The following is a description of a gene set: Mouse Gene Set: CHYLA_CBFA2T3_TARGETS_UP While a number of DNA binding transcription factors have been identified that control hematopoietic cell fate decisions, only a limited number of transcriptional corepressors (e.g., the retinoblastoma protein and the nuclear hormone corepressor) have been linked to these functions. Here, we show that the transcriptional corepressor Mtg16 (myeloid translocation gene on chromosome 16), which is targeted by t(16;21) in acute myeloid leukemia, is required for hematopoietic progenitor cell fate decisions and for early progenitor cell proliferation. Inactivation of Mtg16 skewed early myeloid progenitor cells toward the granulocytic/macrophage lineage while reducing the numbers of megakaryocyte-erythroid progenitor cells. In addition, inactivation of Mtg16 impaired the rapid expansion of short-term stem cells, multipotent progenitor cells, and megakaryocyte-erythroid progenitor cells that is required under hematopoietic stress/emergency. This impairment appears to be a failure to proliferate rather than an induction of cell death, as expression of c-Myc, but not Bcl2, complemented the Mtg16(-/-) defect. studied in species Mus musculus Genes up-regulated in immature bone marrow progenitor cells upon knock out of CBFA2T3. from publication Chyla BJ, Moreno-Miralles I, Steapleton MA, Thompson MA, Bhaskara S, Engel M, Hiebert SW (PMID 18710942), and this is the list of marker genes: Slco3a1, Fnbp1l, Dsg1b, Tmem144, Gca, Tcn2, Tpm4, Grpel2, Gpt2, Bpifc, Vpreb3 (V-set pre-B cell surrogate light chain 3), Dram1, Krt18, Cebpe, Zfp111, F2rl3, Gpr171, C1ra (NCBI Gene Id 50909), F10, Gpr15lg, Tbxa2r, Arhgef2, Fcor, Plod3, Adap1, Smyd4 (NCBI Gene Id 319822), Cracr2b, Slc32a1, Acsbg3, Dusp2, Gstm3, Lpgat1, F2r, Igsf6, Nemp1, Plcg2, Parp8, Prtn3, Ppia, Cd300lg, Tcea2, Ms4a3, Trap1a, Lgr5, Chd9, Bace1, Gm13710, Ttc39c, Prss16, Tmem119, Peli2, Ctsc, Nostrin, 2210408F21Rik, Itm2a, Man1c1, Trem1, Arid5a, Tifab, Ptger2, Npl, 4930417H01Rik, Nr5a1os, H2-Aa, Alox5ap, Idh1, Nkg7, Ear6, Rhobtb1, Cask, Sun2, Ptgs1, Dstn, Eepd1, Clec4d, Afap1l1, Arhgdib, Tfec, Rassf8, Ero1b, Cpne3, Lyzl1, Poglut3, Plpp2, Cables1, Serpina3g, E230032D23Rik, Rsph9, H2bc22, Ubash3b, Fbp1, Tmem53, Slc6a19os, Ucn, Trf, Cdin1, Tek, Casp1, Ldhb, Or2a14, Nav2, Ikbke (inhibitor of kappaB kinase epsilon), Esam (endothelial cell-specific adhesion molecule), Ffar2, Egln3, 1700025G04Rik, Mgst2 (NCBI Gene Id 211666), Mrgpra2b, Trim45, Hvcn1, Tlr12, Cldn15, Mgam, Rab44, Rbpms, Mctp1, Tcirg1, Klf8, Or5ac20, Ass1, Gadd45b, Galk2, Atrnl1, Hes5, Prg3, Ldlrad3, Aatk, BC028528 (cDNA sequence BC028528), Dock9, Pkd1l3, Gchfr, Taf5l, Msantd3, Tmem38b, Unc93b1, Hsd17b1, Bcr, Gfi1, P2rx7, Gbp3, Notch3, Klrb1c, Adgrl4, Id1, Slpi, Appl2, Kcnip3, Rab11fip5, Atp13a2, Alas1, Sla2, Sting1, Nr1h3, Rab31, Fcgr3, Cxxc5, Endou, B3gnt8, 4930486L24Rik, Siglecf, Celf2, Nek6, Zxdc (ZXD family zinc finger C), Mast4, Nrg4, Klkb1, Fkbp11, Ldhc, Elane, Tnfrsf26, Cuedc1, Clec5a, Cyp2j6, Ctsg, Prodh, Tet2, Gzmd, Adgrg3, Cd34, App, Sgms2, Slc35b4, Platr25, 4833407H14Rik, Scamp5, Anxa3, 4930555A03Rik, Sstr2, Plekha2, Olr1, Pam, Cemip2, Mdga1, Ccm2l, Pde2a, Serpina3b, Acod1, Igll1, Ctf1, Plekha1, Ncf2, Mtf2, Hdc, Rnase2a, Hoxb2, Ccnd2, Cd93, Mfng, Slc36a3os, Cxcr4 (NCBI Gene Id 12767), Calr, Il5ra, Dntt, Bambi-ps1, Hnmt, Cd209d, Gmpr, Ggta1, Mcub, Gm5111, Fcgr2b, Gm39348, F13a1, Slc7a6, Thnsl2, Ank3 (ankyrin 3, epithelial), Calml4, Nim1k, Stard8, Tmem141, Mfsd13a, Cideb, Cyth4, 2210406H18Rik, Slc16a9, Phf21a, Sh3bgrl2, Ccdc102a, Cd48, Pld4, Slco4a1, A430019L02Rik, Adss1, Itih5, Sptan1, Stox1, Mir223hg (NCBI Gene Id 100038363), Sh3tc1, Plppr3, Sox13 (SRY (sex determining region Y)-box 13), Ppm1k, Septin6, Pxylp1, Alpk1, Gria3, Gfra1, Arhgef3, Gm48691, Fabp5, Ehd3, Tmem150b, Kalrn, Anxa5, Evi2b, Pgam1, Itpkb, Cfap57 (NCBI Gene Id 77131), Ttpa, Ebf1, Rag1, Mta3, Nalcn, BC035044, Cebpb, Upk3bl (uroplakin 3B-like), Trem3, Arl11, D130052B06Rik, Serpinb2, Depp1, Lrp12, Ebi3, Hk3, Gbx2, Vpreb1b, Prss57, Hp, Rab27a, Homer3, Serpina3m, Cxxc4, Lbp, Gm19590, Ppbp, Tmed3, Dnmbp, Tslp, Arhgef6, Ppp1r14a, Lcp1, Flt1, Lmo1, Socs2, Tnfaip8, Gm36017, Tnfrsf12a, Rasgrp2, Gstm2, Ly6i, Cxcr6, Klhl5, Tsc22d3, Krt7, Or1j10, Clec12a, Abcg1, Nrg1, Slc4a8, Vsig10l, Tesmin (NCBI Gene Id 17771), Gstm1, Atp8b4, Ncf4 (neutrophil cytosolic factor 4), Tmod1, Vat1, Gpr65, Gpr160, 2010013B24Rik, Spef1, Ptprj, 1700040D17Rik, Atp10a, Mgl2, Slc28a2, Ppp1r3b, Laptm5, Rin3, Mefv, Rab27b, Uaca, Zfp709, S100a11, Get1, B4galnt4, Fndc3b, Hivep3, Spns3, Cerox1 (NCBI Gene Id 72834), Serpinb10, Spi1, Ralgps2, Slamf1, Mogat2, Zc2hc1a, Abcd2, Tle6, Vill, Gzma, Bex1, Rnf180 (NCBI Gene Id 71816), 2310075C17Rik, Ccdc125 (NCBI Gene Id 76041), 1700020L24Rik, Stox2, Gmfg, Sptbn1, Ramp1, As3mt, Rhoq, Ern1, Ralb, Thada, Snx24, Cst7, Cx3cr1, Map3k15, Ctla2b, Cda, Elovl7, Csrnp1 (NCBI Gene Id 215418), Cyp2j9, Golga5, Hpgd, Serpinb1a, Gas7 (NCBI Gene Id 320013), Tgfbi, Tm6sf1, Prkcq, Slc45a4, Irf6, Pik3ip1, Prg2, Epx, B4galt6, Ppfibp2, 4931406C07Rik, Tnfrsf1a, P2ry14, Misp, Ppic, Wls, Selplg (NCBI Gene Id 20345), Hpse, Cripto, Myo7a, F2rl2, Plxna4os1, Armcx4, Gstt3 (NCBI Gene Id 103140), Chd7, Ltb4r1, Plek2, Gys1, Rhob, Emp1, Myct1, Hps3, Gprc5a, Clec4e, H6pd, Ica1, E230001N04Rik, Hsd11b1, Slc24a5, Gopc, Eif4ebp2, Krt80, Il21r, Pard3b, Cdk5r1